Given this list of marker genes GLRA1, GABRB1, GRIK2, GRIN3B, GRIA1, GRIK5, GRIK4, GRIN2D, HTR3A, GRIK3, GABRR1 (NCBI Gene Id 2569, gamma-aminobutyric acid type A receptor subunit rho1), GRIA4, GABRA2, GABRA5, GRIN2B (NCBI Gene Id 2904), GRIA3, here is a description of the gene set: Human Gene Set: GOMF_LIGAND_GATED_MONOATOMIC_ION_CHANNEL_ACTIVITY_INVOLVED_IN_REGULATION_OF_PRESYNAPTIC_MEMBRANE_POTENTIAL studied in species Homo sapiens Any ligand-gated ion channel activity, occurring in the presynaptic membrane, that is involved in regulation of presynaptic membrane potential.